Given this list of marker genes Nlrp3 (NLR family, pyrin domain containing 3), Plekha5, Gsdma3, Golph3, Lancl2, Pla2g4e, Mbl1, Gsdma2, Gsdmc2, Dab2ip, Plekha8, Jph2, Osbp, Sh3pxd2a, Sap30l, Obscn, Osbpl5, Gsdma, Snx5, Gsdmd, Rs1, Sh3pxd2b, Arfip1, Sestd1, Rubcnl (NCBI Gene Id 380917), Golph3l, Snx24 (sorting nexing 24), Mbl2, Snx3, Gsdmc, Pla2g4a, Plekha3, Gsdmc3, Gsdmc4, Plekhf1, Cert1, Arfip2, Osbpl8, Washc2, here is a description of the gene set: Binding to phosphatidylinositol-4-phosphate, a derivative of phosphatidylinositol in which the inositol ring is phosphorylated at the 4' position. Mouse Gene Set: GOMF_PHOSPHATIDYLINOSITOL_4_PHOSPHATE_BINDING species: Mus musculus